Given this list of marker genes JAK3, SOCS1, IRS2, RAG1, IL7R, PIK3R1, JAK1, IL7, H3C15, PIK3R2, SOCS2, H3C1 (H3 clustered histone 1), STAT3, PIK3R3, SMARCA4, CRLF2, IL2RG, RAG2, STAT5B, IRS1, HGF, CISH, TSLP, BRWD1, STAT5A, here is a description of the gene set: Reactome Pathway: Interleukin-7 signaling part of: Signaling by Interleukins studied in species Homo sapiens Interleukin-7 (IL7) is produced primarily by T zone fibroblastic reticular cells found in lymphoid organs, and also expressed by non-hematopoietic stromal cells present in other tissues including the skin, intestine and liver. It is an essential survival factor for lymphocytes, playing a key anti-apoptotic role in T-cell development, as well as mediating peripheral T-cell maintenance and proliferation. This dual function is reflected in a dose-response relationship that distinguishes the survival function from the proliferative activity; low doses of IL7 (<1 ng/ml) sustain only survival, higher doses (>1 ng/ml) promote survival and cell cycling.<br><br>The IL7 receptor is a heterodimeric complex of the the common cytokine-receptor gamma chain (IL2RG, CD132, or Gc) and the IL7-receptor alpha chain (IL7R, IL7RA, CD127). Both chains are members of the type 1 cytokine family. Neither chain is unique to the IL7 receptor as IL7R is utilized by the receptor for thymic stromal lymphopoietin (TSLP) while IL2RG is shared with the receptors for IL2, IL4, IL9, IL15 and IL21. IL2RG consists of a single transmembrane region and a 240aa extracellular region that includes a fibronectin type III (FNIII) domain thought to be involved in receptor complex formation. It is expressed on most lymphocyte populations. Null mutations of IL2RG in humans cause X-linked severe combined immunodeficiency (X-SCID), which has a phenotype of severely reduced T-cell and natural killer (NK) cell populations, but normal numbers of B cells. In addition to reduced T- and NK-cell numbers, Il2rg knockout mice also have dramatically reduced B-cell populations suggesting that Il2rg is more critical for B-cell development in mice than in humans. Patients with severe combined immunodeficiency (SCID) phenotype due to IL7R mutations (see Puel & Leonard 2000), or a partial deficiency of IL7R have markedly reduced circulating T cells, but normal levels of peripheral blood B cells and NK cells, similar to the phenotype of IL2RG mutations, highlighting a requirement for IL7 in T cell lymphopoiesis. It has been suggested that IL7 is essential for murine, but not human B cell development, but recent studies indicate that IL7 is essential for human B cell production from adult bone marrow and that IL7-induced expansion of the progenitor B cell compartment is increasingly critical for human B cell production during later stages of development.<br><br>IL7 has been shown to induce rapid and dose-dependent tyrosine phosphorylation of JAKs 1 and 3, and concomitantly tyrosine phosphorylation and DNA-binding activity of STAT5a/b. IL7R was shown to directly induce the activation of JAKs and STATs by van der Plas et al. (1996). Jak1 and Jak3 knockout mice displayed severely impaired thymic development, further supporting their importance in IL7 signaling.<br><br>The role of STAT5 in IL7 signaling has been studied largely in mouse models. Tyr449 in the cytoplasmic domain of IL7RA is required for T-cell development in vivo and activation of JAK/STAT5 and PI3k/Akt pathways. T-cells from an IL7R Y449F knock-in mouse did not activate STAT5, indicating that IL7 regulates STAT5 activity via this key tyrosine residue. STAT5 seems to enhance proliferation of multiple cell lineages in mouse models but it remains unclear whether STAT5 is required solely for survival signaling or also for the induction of proliferative activity (Kittipatarin & Khaled, 2007).<br><br>The model for IL7 receptor signaling is believed to resemble that of other Gc family cytokines, based on detailed studies of the IL2 receptor, where IL2RB binds constitutively to JAK1 while JAK3 is pre-associated uniquely with the IL2RG chain. Extending this model to IL7 suggests a similar series of events: IL7R constitutively associated with JAK1 binds IL7, the resulting trimer recruits IL2RG:JAK3, bringing JAK1 and JAK3 into proximity. The association of both chains of the IL7 receptor orients the cytoplasmic domains of the receptor chains so that their associated kinases (Janus and phosphatidylinositol 3-kinases) can phosphorylate sequence elements on the cytoplasmic domains. JAKs have low intrinsic enzymatic activity, but after mutual phosphorylation acquire much higher activity, leading to phosphorylation of the critical Y449 site on IL7R. This site binds STAT5 and possibly other signaling adapters, they in turn become phosphorylated by JAK1 and/or JAK3. Phosphorylated STATs translocate to the nucleus and trigger the transcriptional events of their target genes.<br><br>The role of the PI3K/AKT pathway in IL7 signaling is controversial. It is a potential T-cell survival pathway because in many cell types PI3K signaling regulates diverse cellular functions such as cell cycle progression, transcription, and metabolism. The ERK/MAPK pathway does not appear to be involved in IL7 signaling.<br><br>It is not clear how IL7 influences cell proliferation. In the absence of a proliferative signal such as IL7 or IL3, dependent lymphocytes arrest in the G0/G1 phase of the cell cycle. To exit this phase, cells typically activate specific G1 Cyclin-dependent kinases/cyclins and down regulate cell cycle inhibitors such as Cyclin-dependent kinase inhibitor 1B (Cdkn1b or p27kip1). There is indirect evidence suggesting a possible role for IL7 stimulated activation of PI3K/AKT signaling, obtained from transformed cell lines and thymocytes, but not confirmed by observations using primary T-cells (Kittipatarin & Khaled, 2007). IL7 withdrawal results in G1/S cell cycle arrest and is correlated with loss of cdk2 activity, both events which are known to be regulated by the dephosphorylating activity of Cdc25A. Expression of a p38 MAPK-resistant Cdc25A mutant in an IL-7-dependent T-cell line as well as in peripheral, primary T-cells was sufficient to sustain cell survival and promote cell cycling for several days in the absence of IL7. Cdkn1b is a member of the CIP/KIP family of cyclin-dependent cell cycle inhibitors (CKIs) that negatively regulates the G1/S transition. In IL7 dependent T-cells, the expression of Cdkn1b was sufficient to cause G1 arrest in the presence of IL7. Withdrawal of IL7 induced the upregulation of Cdkn1b and arrested cells in G1 while siRNA knockout of Cdkn1b enhanced cell cycle progression. However, adoptive transfer of Cdkn1b-deficient lymphocytes into IL7 deficient mice indicated that loss of Cdkn1b could only partially compensate for the IL7 signal needed by T-cells to expand in a lymphopenic environment, so though Cdkn1b may be involved in negative regulation of the cell cycle through an effect on cdk2 activity, its absence is not sufficient to fully induce cell cycling under lymphopenic conditions.